The following is a description of a gene set: species: Mus musculus Any process involved in forming the mature 3' end of a snoRNA molecule linked to prior polyadenylation of the 3'-end of the precursor snoRNA. Mouse Gene Set: GOBP_POLY_A_DEPENDENT_SNORNA_3_END_PROCESSING, and this is the list of marker genes: Exosc5, Exosc10 (NCBI Gene Id 50912), Parn, Exosc4, Exosc3, Exosc6, Exosc2, Tent4b